The following is a description of a gene set: species: Homo sapiens Human Gene Set: HP_SPONDYLOLISTHESIS Spondylolisthesis Complete bilateral fractures of the pars interarticularis resulting in the anterior slippage of the vertebra., and this is the list of marker genes: AGA, RUNX2, CTSK, BMP4, GNPTAB, SMAD3, PABPN1, FBN1, TGFBR2, IDUA, MAN2B1, TGFB2, TGFB3, BMP2, KANSL1, COL2A1, ZNF469 (zinc finger protein 469), MYH3, ZFX, LMX1B, TGFBR1